The following is a description of a gene set: The movement of substances between cells via gap junctions. A gap junction is a fine cytoplasmic channel, found in animal cells, that connects the cytoplasm of one cell to that of an adjacent cell, allowing ions and other molecules to pass freely between the two cells. studied in species Homo sapiens Human Gene Set: GOBP_GAP_JUNCTION_MEDIATED_INTERCELLULAR_TRANSPORT, and this is the list of marker genes: GJA8, MIP, GJA3, GJB6, GJB2, GJB4